The following is a description of a gene set: Mouse Gene Set: MIR_6953_5P Genes predicted to be targets of miRBase v22 microRNA mmu_miR_6953_5p in miRDB v6.0 with MirTarget v4 prediction scores > 80 (high confidence targets). from publication Chen Y, Wang X (PMID 31504780) studied in species Mus musculus, and this is the list of marker genes: Hbp1, Map1lc3a, Pcdh9, Cnnm2, Metap2, Tmem45b (transmembrane protein 45b), Tfdp1, Zfp354c, Kcnc4, Tgfbrap1, Tulp3, Fam167a, Fndc5, Rnf38, Fjx1, Tmem26, Dhrs9, Fut8, Baiap2l2, Foxp3, Ncald, Dgat1, Spry2, Syncrip, Golph3, Ppp1r27, Ltbp4, Cdk19, Slc15a1, Tspan2, Irag1, Pip4p1, Septin9, Vsig4, Mmp9, Ndufs2, Glrx, Gas7